The following is a description of a gene set: studied in species Mus musculus The directed movement of potassium ions from outside of a cell, across the plasma membrane and into the cytosol. Mouse Gene Set: GOBP_POTASSIUM_ION_IMPORT_ACROSS_PLASMA_MEMBRANE, and this is the list of marker genes: Kcnj1, Kcnj11, Atp1a4, Slc12a5, Slc12a6, Atp1b3, Kcnj9, Kcnk9, Kcnj13, Kcnj15, Wnk2, Kcnd3, Hcn2, Kcnj14, Kcnj8, Atp1b2, Atp1a1, Wnk3, Slc12a2, Kcnj12, Wnk1, Dlg1, Atp1a2, Slc12a1, Fxyd2 (NCBI Gene Id 11936), Slc12a3, Slc12a8, Slc12a7, Kcnj4, Abcc9, Kcnj5, Kcnj6, Kcnq1, Atp1b1, Kcne2, Kcnj10, Kcnj16, Atp4b (ATPase, H+/K+ exchanging, beta polypeptide), Slc12a4, Atp12a, Kcnj2, Atp1a3, Kcnh2, Hcn4, Atp4a, Kcnj3, Wnk4, Kcnk5